Given this list of marker genes Apoa1, Apoe, Abl1, Apoc3, Abca1, Nrp1, Rit2, Ralbp1, here is a description of the gene set: studied in species Mus musculus Any process that modulates the frequency, rate or extent of Cdc42 protein signal transduction. Mouse Gene Set: GOBP_REGULATION_OF_CDC42_PROTEIN_SIGNAL_TRANSDUCTION